Given this list of marker genes Ctsg, Dao, F2, Tusc2, Dnase1l3, Nlrp6, Cxcl1, Trem3, Trem1, Pcyox1l, Elane, F2rl1, Ncf1, Arg1, Dnase1 (NCBI Gene Id 13419), Pomc, Cxcl5, Scnn1b, Myd88, here is a description of the gene set: The directed killing of a target cell by a neutrophil. Mouse Gene Set: GOBP_NEUTROPHIL_MEDIATED_CYTOTOXICITY studied in species Mus musculus